The following is a description of a gene set: APC/C:Cdc20 mediated degradation of Cyclin B Mouse Gene Set: REACTOME_APC_C_CDC20_MEDIATED_DEGRADATION_OF_CYCLIN_B species: Mus musculus, and this is the list of marker genes: Rps27a, Anapc10, Cdc16, Anapc7, Anapc16, Uba52, Anapc15, Ube2s (NCBI Gene Id 77891), Cdk1, Anapc2, Cdc26, Ube2c, Ubb, Ccnb1, Cdc27, Cdc23, Anapc5, Ube2d1, Anapc11, Ube2e1, Uba52rt, Anapc1, Ubc, Anapc4, Cdc20 (cell division cycle 20)